The following is a description of a gene set: Mouse Gene Set: GOCC_SPINDLE_MIDZONE studied in species Mus musculus The area in the center of the spindle where the spindle microtubules from opposite poles overlap., and this is the list of marker genes: Plk1, Cenpe, Mapre3, Cdc6, Aurkc, Aurka, Arl8b, Numa1, Mapre1, Map10, Prc1, Ttc28, Ctdp1, Rif1, App, Kif18a, Cdca8, Luzp1, Eml1, Kif18b, Kif20b, Racgap1, Gem, Camk2b, Mapre2, Cttn, Aurkb, Map9, Pkp4, Firrm, Or2a7, Hnrnpu (heterogeneous nuclear ribonucleoprotein U), Cenpv, Cdc42, Unc119, Kif14, Incenp, Arl8a, Rcc2, Ccdc69